The following is a description of a gene set: Mouse Gene Set: GOBP_GERM_CELL_MIGRATION studied in species Mus musculus The orderly movement of a cell specialized to produce haploid gametes through the embryo from its site of production to the place where the gonads will form., and this is the list of marker genes: Cxcl12, Kit, Foxc1, Dmrt1, Cxcr4, Tgfbr1, Cxadr, Pdilt, Prss37, Tgfb1, Itgb1